Given this list of marker genes ALK, PEX2, DARS2, LIN28B, ATP13A2, PTRHD1, CHP1, ATP2B3, PEX10, ELOVL5, TGM6, SLC1A3, XRCC1, INPP5E, NKX6-2, ITPR1, PNKP, GDAP2, KIF1A, AFG3L2, SPTBN2, SCP2, MFN2, LMO1, SOX3, TNR, EEF2, TSPOAP1, SCYL1, TMEM240, TUBB4A, KIF1B, PDYN (NCBI Gene Id 5173), VPS13A, ATXN7, GJC2, TPP1 (NCBI Gene Id 727719), ALS2, FRMD5, TNFSF11, SLC6A3, PRNP, VAMP1 (vesicle associated membrane protein 1), PIK3R5, MECR, MAPT, PLA2G6, PRDX3, SLC35A2, NPHP1, ATXN3, MYORG, GBA1, TCIRG1, ANO10, COQ5, ATXN2, APTX, NDUFA13, DNAJC6, MRE11, SHMT2, AGTPBP1 (ATP/GTP binding carboxypeptidase 1), ATP1A2, CACNA1G, SNX10, CLCN7, HACE1, MYCN, TUBB3, SYNE1, NOP56, CACNA1A, SYT2, UBAP1, FBXO7, ATXN8OS, DHX16, GRM1, MME, PHOX2B, ATXN1, SLC44A1, VPS13D, FXN, KCNN2, TMEM216, VPS41, GBA2 (glucosylceramidase beta 2), ENSG00000288330, PLD3, ATP1A3, SNCA (synuclein alpha), here is a description of the gene set: Abnormal saccadic eye movements Human Gene Set: HP_ABNORMAL_SACCADIC_EYE_MOVEMENTS An abnormality of eye movement characterized by impairment of fast (saccadic) eye movements. studied in species Homo sapiens